The following is a description of a gene set: Human Gene Set: GOBP_NEGATIVE_REGULATION_OF_CELLULAR_RESPONSE_TO_TRANSFORMING_GROWTH_FACTOR_BETA_STIMULUS species: Homo sapiens Any process that stops, prevents or reduces the frequency, rate or extent of cellular response to transforming growth factor beta stimulus., and this is the list of marker genes: PPARG, MIR19A, DLX1, CFLAR, MIR19B1, MIRLET7B, MIR29B1, MIR372, MIR204, IL4, MIR18A, MIR376C, MIR302B, MIR145